Given this list of marker genes HERPUD1, PTPRN2, GPC3, SHC3, MXI1, ISG15, SLC25A5, GALT, MYC, GSTZ1, CELA2A, F12, FLT3LG, SEL1L, UBXN8, SGK1, CCL7, EPHX2, PBX3, LAMP1, MAT1A, CCND2, TOMM20, SEC61B, SMPD1, RPL17, P4HB, DANCR, DPP6, CYB5A, NCOA1, MAOA, KCNAB1, FXYD2, MT1X, TRPV6, LMAN1, ACRV1, UGT2B15, GATM, LSP1, SMAD4, LOXL1, NPY1R, ICA1, CTAG1B (cancer/testis antigen 1B), CLU, GJB1, ONECUT1, YBX3, WWP2, AP1B1, RPL32, PEBP1, PAX6, CPA3, MAPK9, PPIF, PRDX4, DMPK, NRCAM, SLC20A2, KCNJ15, TAF1, GYPC, HNF1B, SLC25A3, C6, NFKBIL1, SLC33A1, RPS10, KRAS, EVX1, GRB14, ARSA (NCBI Gene Id 410), DSTN, ETV5 (NCBI Gene Id 2119), PCK2, PABPC4, RARRES2, HYOU1, RDX, RPS24, CTNND2, NF2, CACNA2D1, NFIB, PRPSAP1, ZNF22, CRYAB, KCNJ4, ACO1, DDT, SMPDL3A, AEBP1, PHOX2B, IL6ST, RPL13, KAT2B, LSS, CLDN10, ACADM, FGL1, RPS7, CYBA, F11, RNASE1, PTH1R, DAP, IGBP1, LGALS2, MYO1F, LMF2, DPEP1, JUN, HDLBP, BTG1, GTF3C1, AMD1, TOB1 (NCBI Gene Id 10140), KANK1, PDE6G, PEPD, MKNK1, PEX1, ACSM3, PTPRN (protein tyrosine phosphatase receptor type N), BCAT2, SSR1, LGALS8, MAPK8IP2, H19, PPOX, GAMT, ZNF32, CDO1, CRYZ, GRB7, CXCL2, PRKAR2B, IMPDH2, MST1, XBP1, TMED10, APLP1, PWP1, ITPRID2, EIF3A, DMD, ACOX1, DENND4A, MAT2A, NTRK2, ANXA4, RBP1, SERPINA5, PDIA5, PCBD1, RPS9, ROM1, CXCL12, MEST, GATD3, SERPINA6, ABCA3, PSEN2 (NCBI Gene Id 5664), MT1B, RPL7A, NR5A2, CRAT, FKBP2, HHEX, REG3A, DMAC2L, GOLGA4, C5 (NCBI Gene Id 727), SRP54, ITSN2, HTT, HSD17B4, PEX6, ALDH1A1, PPP2R1B, GPX3, RFC1, SNHG14, NUCB1, SEC62, SLC1A4, BCAT1, SRPX, DRD2, NUCB2, INSR, RGN, PTP4A1, RAF1, CHRNA7, EEF2, SSR4, here is a description of the gene set: Genes down-regulated in pancreatic ductal adenocarcinoma (PDAC) identified in a meta analysis across four independent studies. studied in species Homo sapiens Pancreatic ductal adenocarcinoma is the eighth most common cancer with the lowest overall 5-year relative survival rate of any tumor type today. Expression profiling using microarrays has been widely used to identify genes associated with pancreatic cancer development. To extract maximum value from the available gene expression data, we applied a meta-analysis to search for commonly differentially expressed genes in pancreatic ductal adenocarcinoma. We obtained data sets from four different gene expression studies on pancreatic cancer. We selected a consensus set of genes measured in all four studies and applied a meta-analysis approach to evaluate the combined data. Of the genes identified as differentially expressed, several were validated using RT-PCR and immunohistochemistry. Additionally, we used a class discovery algorithm to identify a gene expression signature. Our meta-analysis revealed that the pancreatic cancer gene expression data sets shared a significant number of up- and downregulated genes, independent of the technology used. This interstudy crossvalidation approach generated a set of genes that were consistently and significantly dysregulated in pancreatic cancer. Of these, 364 (64.1%) were upregulated and 204 (35.9%) were downregulated in pancreatic cancer. Only 127 (22%) were described in the published individual analyses. Functional annotation of the genes revealed that genes presumably associated with the cell adhesion-mediated drug resistance pathway are frequently overexpressed in pancreatic cancer. Meta-analysis is an important tool for the identification and validation of differentially expressed genes. These could represent good candidates for novel diagnostic and therapeutic approaches to pancreatic cancer. Human Gene Set: GRUETZMANN_PANCREATIC_CANCER_DN from publication Grützmann R, Boriss H, Ammerpohl O, Lüttges J, Kalthoff H, Schackert HK, Klöppel G, Saeger HD, Pilarsky C (PMID 15897887)